Given this list of marker genes TLR6, CDC25C, CCNY, CDKN3, CEMIP, CDKN2A, PDCD4, LTF, DRD4, S100A12, SERPINB3, RASIP1, PDGFRB, FGF1, FLT3, DEFB114, SRC, HMGA2, UVRAG, FGF2, PTPRJ (NCBI Gene Id 5795), FGF18, CDKN1B, AIDA, CD300A, CCNK, RHOA, DIRAS1, PIH1D1, IRGM, TENM1, PTPN22, SYAP1, PIK3CG, RASGRP1, MAP3K7, TSG101, CCNT1, PRKCH, FGF16 (fibroblast growth factor 16), MAPK8IP1, HEG1, INCA1, PIM1, MACROH2A1, CDK5R1, CDK5R2, LATS2, CIB1, TAOK3, THY1, SASH1, BLM, HIPK3, TRIB3, CAB39, TRAF6, MAP3K11 (mitogen-activated protein kinase kinase kinase 11), CCNT2, SNF8, EZH2, LYN, MAP4K2, TRAF2, PDCD10, AGT, FLT1, HGS, BCCIP, CDC6, MST1, SYNPO2, CCNG1, STK38, ERBB2, PIK3R6, MEN1, ERN1, DIRAS3, MAP2K2, SERTAD1, MAP3K10, TRIB2, FGFR1, DIRAS2, CDC25A, RGS14, DUSP1, ADIPOQ, APOE, NEK10, PKIA, CDK5RAP3, RAPGEF2, TPD52L1, MAP3K5, HERC5, KSR1, TFAP4, GTF2H1, PIK3R5, CCNE2, APC, CDK12, MAP2K1, TNF, IFNG, PDGFB, MAP3K4, SIRT1, TRIB1, PAQR3, PYCARD, LATS1, DNAJA1, ARHGEF5, PKMYT1, GADD45A, DIPK2A, ELANE, PTPN1, CDK5RAP1, NPPA, WNT5A, CRIPTO, TCIM, ETAA1, MST1R, RALB, CDC37, CAMK1, PSMD10, DUSP7, here is a description of the gene set: Any process that modulates the rate, frequency, or extent of protein serine/threonine kinase activity. species: Homo sapiens Human Gene Set: GOBP_REGULATION_OF_PROTEIN_SERINE_THREONINE_KINASE_ACTIVITY